Given this list of marker genes Fancm, Birc2, Pef1, Wdr48, Pdcd6, Ubb, here is a description of the gene set: Any process that modulates the frequency, rate or extent of protein monoubiquitination. Mouse Gene Set: GOBP_REGULATION_OF_PROTEIN_MONOUBIQUITINATION species: Mus musculus